Given this list of marker genes ADAM18, RNF17, PRAME, H2BC1, TUBA3C, PPP3R2, TEX12, H1-6, ELOA2, PDHA2, LDHC, ADAM2, DDX4, here is a description of the gene set: species: Homo sapiens To gain insight into the function of DNA methylation at cis-regulatory regions and its impact on gene expression, we measured methylation, RNA polymerase occupancy and histone modifications at 16,000 promoters in primary human somatic and germline cells. We find CpG-poor promoters hypermethylated in somatic cells, which does not preclude their activity. This methylation is present in male gametes and results in evolutionary loss of CpG dinucleotides, as measured by divergence between humans and primates. In contrast, strong CpG island promoters are mostly unmethylated, even when inactive. Weak CpG island promoters are distinct, as they are preferential targets for de novo methylation in somatic cells. Notably, most germline-specific genes are methylated in somatic cells, suggesting additional functional selection. These results show that promoter sequence and gene function are major predictors of promoter methylation states. Moreover, we observe that inactive unmethylated CpG island promoters show elevated levels of dimethylation of Lys4 of histone H3, suggesting that this chromatin mark may protect DNA from methylation. from publication Weber M, Hellmann I, Stadler MB, Ramos L, Pääbo S, Rebhan M, Schübeler D (PMID 17334365) Unmethylated germline-specific genes with intermediate-CpG-density promoters (ICP) in sperm. Human Gene Set: WEBER_METHYLATED_ICP_IN_SPERM_DN